Given this list of marker genes AREG (NCBI Gene Id 727738), TPRG1L, SNAPIN, AP4B1, AP1S1, BCL2L1, SLC17A9, PRKN, CLTC, TMED10, RAB27B, ICA1, SEC24A, VAMP1, GRIA1, TGFA, UNC13A, SYTL4, SLC30A3, DNAJC5, TAFA4, SYT5, SYN3, ATP6V1G2, LRRK2, DYSF, CLTA (NCBI Gene Id 63271), PHF24, HLA-H, SYT12, AP1G2, HLA-DQA1, HLA-DQB2, SYT3, RASSF9, SLC17A6, SYPL1, ATP6V1B2, RPH3AL, SEMA4C, SCAMP1, BTBD8, ABCA12, TMEM184A, SLC30A5, HLA-B, VTI1B, SYT10, MYOF, SEC22B, RAB3A, CNIH2, LMAN1, ABCC8, STX6, CNIH1, SLC35D3, ZNRF1, SYNPR, DMXL2, SLC18A3, STX1A, OPRK1, SYNGR2, RAB3B, ITPR2, PTPRN2, FER1L5, ATP6V0A4, SLC6A2, ITPR1, SV2B, TMED2, AP1M1, ATP6V0A1, DRD2, CLBA1 (NCBI Gene Id 122616), CA4, CD59, AP1B1, SNCA, SCAMP5, STX10, NRGN, SORL1, AP2A1, VMA21, SCAP, CEACAM1, RAB26, PDCD6, RAC1, ATP8A1, HLA-DRB5, SLC5A7, OTOF, SEC24B, RAB1A, SLC35F1, CLCN3, SYNRG, SYT9, HLA-F, SYT1, CPLX3, HLA-C, DGKI, SLC6A17, ARFGEF3, RAB11A, RAB7A, SCG3 (secretogranin III), ATP6V1D, PEF1 (NCBI Gene Id 553115), PAM, HLA-A, SYT6, SLC30A2, HLA-DRB1, SLC35G2 (NCBI Gene Id 80723), HLA-DPA1, HLA-DQB1, HLA-G, MCTP1, BORCS5, STX17, DBH, SV2A, SYPL2, SEC13, PHAF1, KLHL12, SEPTIN8, ATP6V0E2, GABRA2, BIN1, SYT2, ATP2B1, TMEM30A, SAR1A, DTNBP1, STX12, VTI1A, PRRT2, SLC32A1, VAMP7, SYT7, EEF1AKMT4-ECE2, ATP6V1F, SAR1B, MAP6, OPRD1, ATP6AP2, ATP6V1A (ATPase H+ transporting V1 subunit A), HLA-DRB3, CIDEB, CNIH3, RPH3A, ATP6V1E1, SYT8, AP1S2, BSN, TMEM163, RAB5B, SVOP, SYT13, UNC13B, SYN2, SLC9B2, AP1S3, SYNGR3, SCGN, ATP6V0C, LAMP5, ATP6V0D1, HLA-DRA, AP1M2, SLC6A9, SEC23A, KIF1B, CLTB, ATP6AP1, DNM1L, ATP6V1H (NCBI Gene Id 51606, ATPase H+ transporting V1 subunit H), CRYZL2P-SEC16B, CBARP, FOLR1, DOC2A, SYT4, USO1, B2M (beta-2-microglobulin), SEC16B, SYP, SNTB2, GPR151, SEC24C, PRRT1, ATP6V1G3, CD74, SLC18A1, SLC18A2, SLC17A5, WFS1, CALM3, SV2C, PTPRN, SEC23IP, SLC4A8, PTPRS, RAB11B, PPT1, ITPR3, SPRED2, SLC17A8 (NCBI Gene Id 64944), STX5, STX16, SYNGR4, ANP32E, HLA-DQA2, HLA-DPB1, AP1G1, CPE, SEC24D, GOSR2, UNC13C, MCFD2, SEC16A, SYNDIG1, SEC23B, MCTP2, AMPH, NCALD, ATP6V1B1, ATM, RAB11FIP5, TMED7, VAMP2 (vesicle associated membrane protein 2), SYN1, CLTCL1, HLA-DRB4, SLC30A8, SYNGR1, ATP6V1C1, SLC18B1, HLA-E, ATP6V1G1, ECE2, AFTPH, SREBF2, RAB5A, SREBF1, SEC31A, AQP2, SEC31B, ARPC2, SLC17A7, here is a description of the gene set: studied in species Homo sapiens The lipid bilayer surrounding a transport vesicle. Human Gene Set: GOCC_TRANSPORT_VESICLE_MEMBRANE